Given this list of marker genes TMEM170A, P2RX7, AFDN, NUP205 (NCBI Gene Id 23165), TSPAN33, ADAM10, TPR, AHCTF1, GSDMD, NDC1, NUP153, ANO6, NUP93, FXR1, PDZD11, RTN4, PLEKHA7, NUP98, NUP107, BAD, here is a description of the gene set: The aggregation, arrangement and bonding together of a set of components to form a pore complex. A pore complex is a small opening in a membrane that allows the passage of liquids and/or gases. Human Gene Set: GOBP_PORE_COMPLEX_ASSEMBLY studied in species Homo sapiens